The following is a description of a gene set: Human Gene Set: MIR12136 Genes predicted to be targets of miRBase v22 microRNA hsa-miR-12136 in miRDB v6.0 with MirTarget v4 prediction scores > 80 (high confidence targets). species: Homo sapiens from publication Chen Y, Wang X (PMID 31504780), and this is the list of marker genes: SS18, RUNX1, NRXN1, ROBO2, AVL9, KHDC4, APPL1, STK35, GPC4, TMEM196, SCAMP1, ACVR1C, RSPH4A, IL5RA, NEK7, GNAQ, NADK, PPIL4, SORCS3, UBE2B, MOB4, OSBPL3, TOX3 (TOX high mobility group box family member 3), FHIP2A, NAALADL2, HACD4, RAB5B, ARF3, NOTCH2, KARS1, BCL11A, FKBP5, EEA1, KCTD5, KLHL24, FBXO22, ATXN7, DSC3, DTWD2, GLCE, PPEF2, MMS22L, IDH3A, REEP3, FGL2, KMT2E, CCDC34, GALNT4, NFAT5, ADAM17 (ADAM metallopeptidase domain 17), LCOR, NAMPT, SLC11A2, UBE2R2, HMGCLL1, AKAP1, ADD3, GNL3L, SEC61B, LNPK, UBQLN1, SH3GLB2, NEDD4L, PFDN4, MYLIP, TUT4, SCAI, NFE2L2, ABCG2, SLAIN1, SRSF10, TMEM181, MAML1, HEXIM1, C3orf70, CAMLG, YTHDF1, PAK2, ASH1L (NCBI Gene Id 55870), ADK, SCAF4, BRAF, SOX5, ZBTB44, OCLN, NT5E, ABHD13, C21orf91, CYSLTR1, SAV1, MAGI3, SIX4, TSPAN9, PDAP1, ZHX1, MYT1L, AGO1, ACVR2B, CDCA4, GNAI2, GBF1, PRTG, ZC3H6, IPMK, RHBDL2, SKIL, SLC35A3, HNRNPUL1, DYNC1LI2, SUB1, RUNDC3B, INO80D, PARD6B, GUCY1B1, PTRH1, SH3GLB1, ZCCHC3, CXCL14, FBXO33 (NCBI Gene Id 254170), PRR3, NADK2, BCAT1, DESI2, BNIP2, CADM2, NR2C2, ZBTB6, RAG1, LDB2, KPNA1, GALNT13, FAM161A, KHSRP, AP1S3, TAF2, FSTL1, TJP1, KCNT2, ICE2, KATNBL1, HERC4, ARB2A, PRKAR2B, GASK1B, XPR1, PSMD11, NECTIN3, ZBTB7A, STAM, SMIM17, LRIT3, VWC2, SGIP1, CRY1, SEPTIN10, ZNF678, TUT7, DCUN1D1, GK, PCDHA1, SEC61A2, RBM27, PPM1A, TLCD4, LIN54, PLPPR4, ATP6V1C1, PCLO, LYRM7, PAK5, TAL1, PCDHA2, RPS6KA6, BTC, ANAPC16, MYLK, ZNF326, SMPD3, NCAM1, SERPINE2, PRKAA2, GRIA2, VEZF1, SLC17A6, MBNL2, GABRB3, SEC31A, CRLF3, CNTNAP2, ZNF362, LARS1, SCAP, KIF5B, CPNE3, PAN3, SCN2A, PPIP5K2, ARL5B, SEC24A, DNMT3B, RBM39, ID3, PRKAA1, ZDHHC20, CREBRF, PSMA2, PPP3CA, FBXO42, COA5, PRRG4, RBFOX2, PUM2, ERO1B, NELFA, SLC6A15 (NCBI Gene Id 59276), SYNJ2BP, PSD3, B3GLCT, ULK2, ZNF236, SECISBP2L, SERTAD2, MAP4K3, PHTF2, TWSG1, HDAC9, CREB1, NXT2, UBE2K (ubiquitin conjugating enzyme E2 K), SFMBT1, ACVR1 (activin A receptor type 1), RWDD4, MCUR1, PCDH20, CHIC1, MCM6, PLOD2, OSBPL8, ATP6AP2, ELAVL3, KCNQ5, SYT4, TMEM68, CELF4, KLHDC1, LDB3, UBE2D3, CDV3, ANXA4, RC3H1, RBM6, LY75, ATXN1, BCL2L2, CCDC88A, HIPK2, TNRC6C, TMEM170A, ARL8B, SYNE3, PPAT, AHCTF1, PELI2, OTULIN, PARP12, GRM5, SINHCAF, TNPO1, CCSER1, IL26, DBT (dihydrolipoamide branched chain transacylase E2), FABP7, RNF138, PPP1CC, COL25A1, AAK1, TCEA1, RTKN2, CKAP5, FAM76B, ZNF737, NTRK2, KDSR, EOGT, CYTH3, SRF, C11orf87, TGDS, CDK6, TMPRSS11D, PCDHA5, ACP3, TPGS2, PKIG, ALDH1L2, AEBP2, RAP2C, ADGRB3 (NCBI Gene Id 9664), NFIA, GTF2H1, PIK3CA, SLC35F3, MBTD1, TOB2, PRDX6, RORA, ACSL6, FRMD4B, ZNF112, PRKACB, TSHZ1, TBR1, TASOR, LRCH2, SOX8, GRIP1, PHACTR2, SUMO2, BPNT2, ANKRD27, CACUL1, TMEM127, DCX, PHLDB1, UBE2H, EIF5A2, MED13, ZCCHC8, SMC6, UBR5, ARPP19 (cAMP regulated phosphoprotein 19), STRBP, EMC8, APPBP2, FECH, PRPF39, ZNF503 (zinc finger protein 503), RAD21, NOTCH1, TMEM135, CPEB1, KCNA1, DUT, GSPT1 (NCBI Gene Id 2935), ZFC3H1, ZEB2, PLEKHJ1 (NCBI Gene Id 55111), ANKRD13A, HECW2, SGMS1, DIPK2B, NAA25, ATP11C, MID2, PCDHA11, C3orf80, PPP2R2A, WIZ, TFDP3, ACVR2A, GIT2, DKK2, GRTP1, ZC3H12C, PRND, C5orf24, RYBP, LPAR1, SSH2, AGO4, PCDH15, LRP8, PCYT1B, HOOK1, FBXO32, PCDHA3, ELP4, SLC39A14, PPP1R9A, HIPK3, TAB3, GRB10, DPYSL2, ZNF714, DCUN1D4, MYO6, MFSD8, BAZ1A, RAB5IF, MTURN, GK5, SORBS2 (sorbin and SH3 domain containing 2), LCA5, SLC4A7, FAT4, PTBP3, AMOT, SAMD12 (sterile alpha motif domain containing 12), CEP97, TM9SF2, PHIP, LUZP2, KAT2B, MKX, PLK2, PDSS1, CTDSPL2, PTAR1, CLEC12B, TNRC18, ARK2N, ZFAND4, CPED1, SOS2, CCDC148, ZMAT3, STRN, SLAIN2, PDE4B, ZFHX3, COL11A1, TMEM65, STAT3, EVI5, PTPRG (protein tyrosine phosphatase receptor type G), SSR1, KANK1, MAPK1IP1L, ARMCX3, RBPJ, PTPN2, TULP4, EGR3, GABRA1, EZH2, KLF9 (KLF transcription factor 9), CARF, RBM41, CDC42BPA, TRPS1, EIF2AK3 (NCBI Gene Id 9451), AHR, RAPH1, JADE3, ELAVL2, PPP1R21 (protein phosphatase 1 regulatory subunit 21), STAT5B, ITGB1, SLC5A3, MIDEAS, PTPRK (protein tyrosine phosphatase receptor type K), FNDC3A, CCP110, UBR2, CUL5, SLC7A2, MMD, SCN9A, SORCS1, SCML1, PCDHA8, RCBTB2 (RCC1 and BTB domain containing protein 2), UBE2W, TRPM8, TPST2, ST13, NALF1, KCNN3, LRRN1, CDKL5, CILK1, CD24, CSNK1G1, ZCCHC18, RALGPS2, MBNL3, UBE2D1, TMEM67, LATS2, ECPAS, PCDHA13, NRARP, NCKAP1, RNF8, CPNE8, USP46, SOX21, CYB5R4, ILF3, PECR (NCBI Gene Id 55825), TOX, ADCY7, MTF1, IL6ST, TMPO, SLC4A4, CALU, MOB1B, SUPT3H, PARD3B, TENM1, DENND1B, PAFAH1B2, TM9SF1, MARCKSL1, KMT5C, KPNA4 (NCBI Gene Id 84857), LUC7L3, FBXO9, NR4A3, RAI14, USP12, SLC20A2, PRKG1, PNISR, ACTR3, TMEFF2, MICU3, HIPK1, LHX9, B3GALT2, DNAJB4, ETNK1, XRN1, ZBTB25, RBMS3, SLC30A7, KLHL15, ABCB10, KCNK2, RELL1, EEIG2, STXBP5, SERBP1, MYNN, SLFN5, MEX3D, HDAC4, FGD4, HNRNPH3, SKI, ARGLU1, ZFP36L1, HMBOX1, TRAK2, TMX3, CNOT6L, DNAH12, UBE4A, SDK1, NPTN (neuroplastin), UNC5D, CDC73, HSPE1-MOB4, BCL10, TRIP11, SPTY2D1, NUB1, ELOVL5, PRRC1, THSD7A, ATL2, MZT1, TENT2, SGMS2, SOX6, ZNF423, ERICH2, FLRT3, MAPK1, ZNF322, VGLL3, ST8SIA4, PLCXD3, CXCR4, TSPAN2, PROM1, PEX5L, FZD3 (NCBI Gene Id 7976), GOLPH3, PACC1, NAV1, CRACD, PCDHAC2, MTM1, ECT2, PRR14L (NCBI Gene Id 84194), ANKS1B, UBR3, KMT5B, CBX5, TTC28, CLOCK, BICRAL, SKIDA1, LSM8, TOLLIP, TM9SF3, PRP4K, EFR3A, TFAP2C, RNF2, USF3, NEUROD1, NCOA3, ABCA1, PCDHA4, CDH7, USP44, G0S2, ID2, ZNF713, EPHA7, AREG, APAF1, ZNF652, OAZ1, DGKH, SLC35F1, SLC30A4, LMBR1, FNIP2, CHD6, EEF1A1, BTBD7, BRWD3, FHIP1B, USP37, CHD1, YTHDF3, MYEF2, SEPTIN7, NR4A2, NEURL1B, PCDHA7, DAAM1, MEGF11, CPEB3 (NCBI Gene Id 22849), NFIB, SCN7A, ARID4B, CACNB4, RNF146, RND3, OGFRL1, PRTFDC1, ZBTB2, VAPA, BCL11B, SOCS4, YES1 (NCBI Gene Id 7525), CNTLN, IRF1, NEMP2, ASB8, MFSD14B, DPYS, GPM6A, SMAD1, MBTPS2, PEX3, TLL1, DERL1, CACNA2D3, CTBP2, OTUD7B, RELCH, SNX18, FSTL5, IL22RA2, TTC32, PMP22, HOMER1, TTC3, SLC7A11, ADAMDEC1, UTP25, IFT70B, CORO1C, PGAP1, CCNA2, HFM1, SETD2, FOXP1, VCAN, FZD6, KITLG, RBMS2, SPRED2, BRD3, CASK, SPTBN1, SP1, PAG1, ETS1, IGFBP7, PALS2, HOOK3, ACTL6A, RNF212B, PDLIM5, ING5, BACH2, NUDT21, USP24, ATXN2L, CEBPB, SFRP5, PCDHA10, TMA16, SLC2A13, RCHY1, HLTF, CAV1, SAR1B, SNW1, PPP1R2, PLPPR5, NUCKS1 (nuclear casein kinase and cyclin dependent kinase substrate 1), SESN3, MRPL19, MDM4, SOCS6, BAG2, ARHGAP12, ARL5A, WDR26, TNFAIP6, MAGT1, KLF8, YAP1 (NCBI Gene Id 10413), PTGFRN, PIAS3, MEF2A, IRF2BP2, ZMYM3, EXD1, LRRC58 (NCBI Gene Id 116064), TMEM150A, CDC5L, TRIM65, PIGK, ZMYM2, TUSC3, IRAK1BP1, IFT70A, SMIM14, IGFBP1 (insulin like growth factor binding protein 1), DCP2, RC3H2, MTA1, PCDHB9, SPATA6, GUCY1A2, USP9X, IKZF2, NEO1, PTP4A1, RAB14, FGF14, KDM4C, TMEM64, SP3, DDX60, ACAP2, SMNDC1, DUSP8, MAST3, AGTR2, USH2A, PPP6C, EIF4E3, EHMT1, CSRNP3, MIGA1, ZFHX4, SIRT1, DNAJC15, MDFIC, GPR137C, SIM2, CDC42SE2, RDH10, SIN3A, CHST9, MGAT4A, PTPRE, PCF11, SLC19A2, KLF6, OGN, RAB30, IDE, BCL2L11, ZFP36L2 (ZFP36 ring finger protein like 2), ECHDC1, ADAM22, COL19A1, ACER3, TRIO, GTF3C3, TENT4B, IFNGR2 (interferon gamma receptor 2), RPS6KA5, ZNRF2, SMAD2 (SMAD family member 2), MED13L, CCDC158, SF3A1, IRX5, PVR, NAGA, DOCK4, TXN, POLH, VIM, SLC35E2A, RUNX2, RFX7, TRPM7, PROSER1, NXF1, ANKRD12, PPM1D, RIC1, TMEM236, GDNF, SMARCE1, NRIP1, SHISA3, FAM98A, DDX3X, NUDCD1, WWTR1, ANKRD10 (ankyrin repeat domain 10), SMG1, STAM2, NOTUM, LIMCH1, CLCC1, POU2F1, PPP1R27, OSGIN2, HYCC2, XPOT, BAG4, POLR2E, ATP13A3, GPR183, EPCAM, ZNF148, HNRNPU, TNRC6B, PCNX1, PCDHA12, TAFA2, ZDHHC3, C6orf47, TMED7-TICAM2, ZBTB20, ERC2, PROK2, PIWIL1, ZNF704, GATA2, INTS2, PRRG3, STX17, ETV1, TRIM36, PCDHA6, UNK, PRKD3, NF1, SPRED1, PSMD5, CCNT2, FAM135A, SON, ZIC3, EYA1, PRKCI, PYROXD1, POLR2H, MIER3, EBF1, NCL, GAB1, EFNB2, SNX16, PCDHAC1, CXCL3, CPEB2, ZNF608, SLC35D1, PPFIA1, TAOK1, MAP3K2, TMEM120B, RHPN2, INPP5A, PLAC8, GSK3B, AHDC1, DYRK3, GNA13, DNAH8, CAMK4, CCBE1, GTF2A2, BRPF3, KDM5A, MAF, FGFR1OP2, MAP3K20, SLC9B1, IGSF11, PM20D2, RSBN1, SUZ12, TMEM87A, TWF1, MYOT, SEL1L, SLC38A2, TBL1XR1, DNAH10, RB1CC1, TTC14, XPO4, YTHDF2, MFN1 (mitofusin 1), COL12A1, CDK19, B3GALNT1, NUFIP2, EREG, STK17B, ATAD1, EGLN1, USP25, YTHDC2, PARP8 (poly(ADP-ribose) polymerase family member 8), CNOT6, OSBPL6, HNRNPA2B1, ONECUT2, TFDP1, CPNE4, AP4E1, SYT14, DLX5, CXCL9, POC1B-GALNT4, RETREG1, TCEAL8 (transcription elongation factor A like 8), AP3B1, EPB41L5, LRRC49, SMAD5, MED14, FAM168B (NCBI Gene Id 130074), JAG1 (jagged canonical Notch ligand 1), SSH1, PHC3, PDCL (NCBI Gene Id 51420), IVNS1ABP, NETO2, TUBE1, SAR1A, ARHGEF26, CLCN3, DHRS7, FLVCR1, RXYLT1, CYBRD1, SUMO1, SGTB, KCTD12, CSPG5, NOL4L, SPPL2A (signal peptide peptidase like 2A), MOSPD1, SSBP3, STX16, GRIK2, ABCB1, MBD2, POTEF (NCBI Gene Id 728378), SIMC1, GOLGA3 (golgin A3), PLXNC1, BMP3, FBXO28, SRSF2, GPR137B, PFKFB4, LHFPL3, RFX3, SMARCAD1 (SWI/SNF-related, matrix-associated actin-dependent regulator of chromatin, subfamily a, containing DEAD/H box 1), SNX9, QNG1, NUP205 (nucleoporin 205)